The following is a description of a gene set: Human Gene Set: HAY_BONE_MARROW_CD34_POS_ERP_EARLY studied in species Homo sapiens from publication Hay SB, Ferchen K, Chetal K, Grimes HL, Salomonis N (PMID 30243574), and this is the list of marker genes: EMID1, SLC40A1, ATF7IP2 (NCBI Gene Id 80063), AMHR2, PDZD8, ZNF385D, PHTF1, STXBP6, CCNG1, PKIG, GIHCG